The following is a description of a gene set: The attachment of presynaptic membrane to postsynaptic membrane via adhesion molecules that are at least partially embedded in the plasma membrane. Mouse Gene Set: GOBP_SYNAPTIC_MEMBRANE_ADHESION species: Mus musculus, and this is the list of marker genes: Cdh9, Lrrc4b, Elfn1, Pcdh8, Lrfn5, Pcdh17, Ntng1, Cdh6, Mapk14, Magi2, Slitrk2, Efna5, Ntng2 (NCBI Gene Id 72451), Slitrk1, Taok2, Nrg1, Gpc4, Igsf9b, Itga3, Lrrc4, Lrfn3, Il1rap, Cadm4, Elfn2, Ptprf, Cdh10, Tenm3, Lrfn4, Nlgn1, Mdga1, Slitrk3, Il1rapl1, Flrt3, Tenm4, Nrxn1, Cadm1, Ptprd, Sparcl1, Slitrk5, Epha3, Mdga2, Lrrc4c, Ptprs